Given this list of marker genes TAF4, NEFH, TELO2, TCTN3, ZMPSTE24, MBD5, TRIP11, PDE11A, KCNJ11, TOPORS, CAVIN1, PRR12, NOP56, WNT5A, RBM10, TBX15, KY, MT-TE, SCNM1, SMAD4, DNMT3B, FAM149B1, FDX2, TMEM216, SET, MFN2, ZFX, COL7A1, SEC23B, SDHB, PON3, NEFL, TBCK, KRT14, NRXN1, TPO, ANXA11, GTF2IRD1, B9D1, CHCHD10, POGZ, CNTNAP2, FTO, GSN, POLR1B, TG, PON1, METTL27, MATR3, PKP1, SDHC, PIGB, HELLS, NFASC, KDM5C, MYMK, PAX8, LHX3, BCR, DDX59, MAN2B1, UHRF1, IFT80, RMRP, DYNC2I2 (NCBI Gene Id 89891), RERE, ECEL1, SMO, CCNF, RTL1, PLCB4, FLNA, RFC2, PPARG, TCOF1, PTPN22, CSNK2A1, SLC25A24, NEK1, RNU4-2, TRIM37, CEP120, SMARCB1, FZD2, PRPH, ATXN2, POU4F1, SQSTM1, GNPTAB, VAPB (NCBI Gene Id 9217), IFT140, PRKAG2, PON2, SBF2, OPTN (optineurin), CPLANE1, SOX9, GMPPB, KLLN, RBBP8, COL11A2, BSCL2, P4HA2 (NCBI Gene Id 8974), NKX2-1, KRT6A, RIPK4, POU1F1, MUSK, HMBS, PRKAR1A, ECM1, HLA-B, POMT2, EXOSC3, MCTP2, SLC6A19, MEF2C, SOD1, TMEM237, CCDC22, ERLIN2, CFAP410 (cilia and flagella associated protein 410), IDS, AGA, WNT10A, COL11A1, IRF6, PPARGC1A, ARID1A, CRPPA, ANG, SPTBN1, FBXO28, TAF1, TAF15, ALG8, TMEM270, HLA-DRB1, GLI3, KCNMA1, HESX1, PANK2, CSNK2B, CAV1, IGHMBP2, FRG1, NFIX, AMPD2, ACTB (actin beta), KCNQ1OT1, RAB34, GNE, SNIP1, DVL3, VPS37D, ALG3, MID1, DHX30, ELN, LMBRD1, RNF125, TBX22, VPS33A, NCF1, TMEM107, CCDC47, GAA, FUS, IGF2, PABPN1, RALGAPA1, CRKL (CRK like proto-oncogene, adaptor protein), DUOX2, HEXB, SOX5, GTF2IRD2, POLR1D, FRAS1, FIG4, BAZ1B, SAA1, LMNA, BMP4, GLB1, PSMB8, ADGRG1, CSPP1, NEU1, MEG3, BUD23, GNS, MMACHC, POMGNT1, EIF4H, CUL4B, RPGRIP1L, ALG6, DNAJC30, TBK1, SNRPB, PLAGL1, GJB2 (gap junction protein beta 2), LIMS2, KCNN3, TREM2, RPGRIP1, LIFR, TBL2, MORC2, DCTN1, OFD1, IL36RN, SLC46A1, ZFP57, ABCC8, SLC26A4, PRRX1, KIF7, FAM20C, TRAF3IP2, IL6ST, ZBTB24, ENG, VPS13B, PROP1, RSPO2, ARSB, GPC4, FOXE1, IYD, CEP290 (centrosomal protein 290), FOXG1, VAC14, LMNB1 (lamin B1), GTF2I (general transcription factor IIi), CUBN, ACVRL1, DNM1, FIBP, CHD6, GNAI3, CPSF3, TCTN2, PI4KA, DAO, PFN1, EDNRA (endothelin receptor type A), PTDSS1, SNRPN, NKX2-5, PTH1R, SLC35C1, DOK7, PQBP1, FKBP6, C2CD3, KMT2D, NEK9, MED25, CDCA7, OCA2, GRHL3, KCNH1, GPR101, INSR, KRT5, LAMA2, SLC35B2, INPP5E, LHX4, HDAC9 (NCBI Gene Id 9734), FREM2, GPC3, SNX14, AIP, TSHB, KIAA0753 (NCBI Gene Id 9851), POP1, STX1A, ROR2, RAB3GAP1, RAB3GAP2 (NCBI Gene Id 26114), VCP, ATP6V1B2, SGCG, WDR35, POMT1, CLTRN, AGPAT2, FOS, PLXND1, SLC39A4, SLC5A5, CDKN1C, UBE3A, HS2ST1 (heparan sulfate 2-O-sulfotransferase 1), MKS1, HNRNPA1, H4C5, TGDS, RPS6KA3 (ribosomal protein S6 kinase A3), CLIC2, TRMU, SREBF1, LARGE1, SRPX2, TMEM231, SH3TC2, MED13L, BTK, AKT1, THRA, PEX16, PTEN, GDF2, MGAT2, MAN2C1, CDC42BPB, SLC37A4, SPTLC1, FBXO11, FUCA1, DHCR7, AFF3, AFF4, TXNDC15, LIMK1, FAM111A, POMK, MAPK1, CHMP2B, FKRP, ALX3, ZNF699 (NCBI Gene Id 374879), SDHD, TSHR, IPO8, USF3, PIGS, HNRNPK, SETBP1, TMEM67, OTX2, CC2D2A, PIK3C2A, DLK1, PDE6D, MMP1, COG1, B9D2, COL2A1, TCTN1, DUOXA2, DVL1, GRIP1, GRIK2, GLE1, SLC52A3, ADNP, GLT8D1, IDUA, GUSB, HYMAI, VPS13A, PIK3CA, NXN, UBQLN2, DYNC2H1, ATRX, PIGW, TARDBP, PEX1, AP1S3, COG7, KCNH5, HRAS, MYMX, AMN, DYNC2I1, EDN1, SMARCA4, POLR1C, CLIP2, RUNX2, EHMT1, KCNQ1, ERBB4, UNC13A, REV3L, LMNB2, here is a description of the gene set: Abnormal tongue morphology Any structural anomaly of the tongue. Human Gene Set: HP_ABNORMAL_TONGUE_MORPHOLOGY studied in species Homo sapiens